The following is a description of a gene set: Human Gene Set: REACTOME_TRANSCRIPTIONAL_REGULATION_BY_MECP2 studied in species Homo sapiens Transcriptional Regulation by MECP2, and this is the list of marker genes: CAMK2G, GRIA2, TNRC6B, FKBP5, NOTCH1, PTPN4, HTT, HDAC1, HIPK2, SGK1, AURKB, TBL1X, MIR132, GPS2, CAMK2A, TNRC6C, PTPN1, HDAC2, MIR137 (microRNA 137), MEF2C, BDNF, AGO1, OPRK1, DLL1, FOXG1, CAMK2B, PPARG, AGO2, HDAC3 (histone deacetylase 3), DGCR8, OPRM1, TBL1XR1, CRH, MET, SIN3A, MOV10, SST, TNRC6A, CREB1, MOBP, SLC2A3, IRAK1, TRPC3, CALM1, GRIN2A (NCBI Gene Id 2903), NCOR1, PTEN, GAD1, CAMK4, SOX2, AGO4, AGO3, GAMT, CAMK2D, PVALB, MECP2, GRIN2B, LBR (NCBI Gene Id 653311), RBFOX1, PRKACA, NCOR2, GAD2 (glutamate decarboxylase 2), GPRIN1